The following is a description of a gene set: Human Gene Set: GSE5589_LPS_VS_LPS_AND_IL10_STIM_MACROPHAGE_180MIN_UP Genes up-regulated in bone marrow-derived macrophage (180 min): LPS versus IL10 and LPS. IL-10 or IL-6 stimulation of control 129xC57BL/6 murine bone marrow derived macrophages in the presence of LPS. We used microarrays to detail the global programme of gene expression changes in response to IL-6 or IL-10 stimulation in the presence of lipopolysaccharide. BMDMs were isolated from control, IL-6-/-, and IL-10-/- mice on a 129XBL/6 mixed background mice and differentiated in the presence of CSF-1 for 6-7 days. Cells were scraped and plated in 6 well plates at 2x10e6/well. Cells were washed with complete DMEM and rested for 1-2 hr before stimulation with combinations of IL-10 (10 ng/ml), IL-6 (2 ng/ml) or LPS (100 ng/ml) for 45 min or 180 mins. Complete biological replicates were performed. from publication El Kasmi KC, Holst J, Coffre M, Mielke L, de Pauw A, Lhocine N, Smith AM, Rutschman R, Kaushal D, Shen Y, Suda T, Donnelly RP, Myers MG Jr, Alexander W, Vignali DA, Watowich SS, Ernst M, Hilton DJ, Murray PJ (PMID 17114459) studied in species Homo sapiens, and this is the list of marker genes: GAS7, SELENOO, PCNA (proliferating cell nuclear antigen), IER5, ADH1C, SAMSN1, METTL18, PITHD1, RFC2, MTURN, ARHGEF7 (NCBI Gene Id 8874), IFI30, GUSB, WDR7, PKP4, SLC25A23, PIK3IP1, SLAMF9, LPXN, COX4I1, NLRC3, ASAH2, RFWD3, AKAP9, PDE7B, N4BP2, SLC25A13, NCAPG2, QPCT, BORCS7, MMS22L, PRR5L, C1QA, FCGR2B, CCR3, GDE1, CD200R1, SPAG7, TRMT10B, NCBP2AS2, TNFAIP8, C8orf33, MTUS1, SDF2, HTR2B (5-hydroxytryptamine receptor 2B), SERHL2, HDAC9, CENPA, HIGD1C, FBXL17, DENND5A, TMLHE, XYLT2, NAGLU (NCBI Gene Id 4669), CISH, CNRIP1, ANPEP, HPSE, RALGPS2, L1CAM, ULK2, KIF3A, CHCHD10, HACL1, TMX4, ALAS1, MFSD6, TP53BP1, CCPG1 (NCBI Gene Id 9236), PCTP, SPACA9, ITGA1, PEX3, BMP2, TMEM50B, TP53INP1, SIGIRR, PDP1, FOLR2, CCR5, MEX3B, ELF2, TBC1D9B, GSG1L, LAT2, LETMD1, IL21R, ANXA3, CTSB, RFC1, FCGR3A, SNX14, CD84, TCEAL9, ARAP3, RNASET2, PEDS1, FCGR2A, PRKG1, HSDL1, MRGPRE, ASL, HLA-DMA, KCNAB2, MPC1 (NCBI Gene Id 51660), RGS18, CXCL11, MID1IP1, SLC14A1, ENG, ACAD8, NAT9, ESR1, UBAP2L, SYT11, DKK2, ERMN (NCBI Gene Id 57471), RABGGTA, AIFM2, MEAK7, PEF1, CDKL2, KYNU, CPQ, NPPC, MAMDC2, FGF13, TENT5C, SAP30L, ARHGAP33, MXD4, CD74, XDH, LYST, CLEC6A, ZNF318, DHRS4, CPD, PIGC, SUMF1, CEP83-DT, LRRC27, GLB1, C3orf70, ST3GAL5, ITGAX, ACAD10, PDLIM4, WBP11, PLAAT3, KCTD2, TMOD1, DEF6, FAM117A, RIDA, VWF, CLK3, FAT3, GPX3, PGD, STX3, RABEP2 (NCBI Gene Id 79874), HTRA2, BCL2A1, LAMP2, FCHSD2, HK3, KIF16B, ENSA, NPY, BRDT, RAF1, TTL (NCBI Gene Id 150465), MOB2, MMP12, WDR19, DCSTAMP, EDEM2, BIVM, CBR1, ADAMTSL5, SLAMF8, CD14, RNF149, RSPH3, TTLL5 (NCBI Gene Id 23093), CHST14, SLC39A8, NUPR2, TEX261, PTGS1, CST7, TCP11L2, CRLF2, CX3CR1, DCAF6, PIP4K2C, BHLHE23, CD1D, SLC35F5